The following is a description of a gene set: species: Homo sapiens from publication Kerkar SP, Goldszmid RS, Muranski P, Chinnasamy D, Yu Z, Reger RN, Leonardi AJ, Morgan RA, Wang E, Marincola FM, Trinchieri G, Rosenberg SA, Restifo NP (PMID 22056381) Myeloid-derived cells comprising the tumor stroma represent a heterogeneous population of cells critical to the structure, function and growth of established cancers. We have recently found that engineering tumor-specific CD8+ T cells to secrete IL-12 (IL-12TD) can lead to striking improvements in T-cell activity against established melanomas in murine models. Surprisingly, IL-12-dependent enhancement of CD8+ T-cell anti-tumor function did not occur through direct ligation of receptors on lymphocytes or NK cells. Instead, IL-12 sensitized host bone marrow-derived tumor-stromal cells, partly through interferon-gamma, to indirectly enhance the effects of adoptively-transferred T cells. Direct presentation of antigen by tumor was not necessary, but MHC class I expression on endogenous cells was essential for IL-12 mediated anti-tumor enhancements. Upon successful treatment with IL-12TD cells, we observed the selective elimination of tumor-infiltrating CD11b+ F4/80+ macrophages, CD11b+/ClassII+/CD11c+ dendritic cells and CD11b+/Ly6C+/Ly6G- but not CD11b+/Ly6C+/Ly6G+ myeloid-derived suppressor cells within regressing lesions. These results are consistent with a model whereby IL-12 triggers the maturation of myeloid-derived cells into competent antigen cross-presenting cells. Licensed recognition of these antigens by effector T cells may in turn trigger the collapse of the tumor stroma and aid in the regression of large vascularized lesions. Human Gene Set: GSE29164_UNTREATED_VS_CD8_TCELL_TREATED_MELANOMA_DAY7_DN Genes down-regulated in B16 melanoma (day 7): untreated versus adoptive transfer therapy., and this is the list of marker genes: BCAT2, SCNN1B, ARHGEF12, LURAP1L, CASKIN2, OR7C1, MINK1, ARHGEF28, SKP1, CNN1, EVI2B, ARID3B, DHX8, DCC, ATP5PO, KIAA1614, SLC38A3, ELAC2, VHL (von Hippel-Lindau tumor suppressor), TRIT1, PDGFA, TCF7, PTOV1, MYC, HYOU1, MAPK13, SLC30A4, CA7, COL27A1 (NCBI Gene Id 85301), GOLGA7B, ODF1, DCTPP1, DIRAS1, LIX1, PPFIA4, LRRC3B, DNMBP, ARR3 (arrestin 3), FAM167B, ADARB1, MAGED1, NAAA, HSPA12A, FBXO36, NAPSA, SYCN, CTRC, APOD, SLC52A2, CNTFR, SLC37A1, TNFRSF11A, LRRC1, SHANK3, SEMA6C, UBE2I, OR10A4, UPK1B, THSD7B, PDZD11, FUNDC1, SLC12A3, SNX21, HSD17B8, CMTM2, CTDP1, LIMCH1, MAP9, FLACC1, CMTM5, SERPINE1, SSBP4, PEX11G, THEMIS2, AHSG, EPHX1, WDR83OS, SMAD7, OTOG, NHERF2, SCNM1, TANC1, RPUSD1, GPBP1L1, EPCAM, EXTL3, LIN37, RBFOX1, C1orf216, FXYD1, CNTNAP2, UBE2S, GJD4 (NCBI Gene Id 219770), ATP1A2 (ATPase Na+/K+ transporting subunit alpha 2), LENG8, ALDH4A1, NCKAP1L, RPL6, FAM162A, FTH1, SLC29A4, GATD1, ITM2A, FGD6, CRPPA, PRR9, STS, C12orf57, ZNF358, SLCO5A1, AIF1L, GJB4, GCM1, PDE4A, RPH3A, STARD3NL, ZDHHC14, LLCFC1, OR52A1, ST6GAL1, DOCK5, LCK, TRAF1, TBC1D22B, FHIT, GOT1L1, HLA-DRA, ASIC4, PSMG4, NOL12, LRRC23, ELN, TMEM54, KDM6B, RNF167, RNF150, FLNB, SH2D1B, UGGT2, SLC31A2, SLAMF1, VAT1, EMD, LIM2, DHRSX, IFT43, CAV1, NCKIPSD, FADS2, TSPAN18, FYN, RTL5, NECAB2, EXOSC5, PRAF2, CYP8B1, ARMCX2, TSPAN7, PKIB, TMEM64, PRRT4, RHOF, CACNG6, SF3B3, EFHD2, DNM2, FBXO10, KRT79, SPRR2A, MRPS27, DIABLO, LY6D, FSTL1, TMEM138, TCTN2, TESK1, CXCL16, INS, CLNK, SIX2, UBE2L3, KRT72, SH3GL3, TMPRSS6, VPS72 (vacuolar protein sorting 72 homolog), FOXP4, CEP170B, GLI2, CRTC1, RPS9, JSRP1 (junctional sarcoplasmic reticulum protein 1), EVI5L, PLEKHO2 (NCBI Gene Id 80301), COL25A1, POP7, TEX35 (testis expressed 35), UCP1, PTRH1, SELENOO, CDH10